Given this list of marker genes NAA15, RNF111, CDH22, CCNT2, NINL, PLAG1, LRRC4C, PPP2R5E, ZBTB4, TMEM161B, RNF141, KIN, SMARCA2, FAM222A, RBL2, NOVA1, TSPAN5 (tetraspanin 5), EDEM3, SIK2, ADAMTSL3, SRF, CDC42, SOBP (sine oculis binding protein homolog), USP11, RREB1, SLC4A4, SLC26A9, DNMT3A, FOS, PDS5B, CDK17, ACTG1, NACC1, ABCA1, MTOR (mechanistic target of rapamycin kinase), FXR1, GOLGA8B, ARHGAP24, RAB2B, ZFAND4, GOLGA6L9, C1orf21, EBF3, AEBP2, MAN2A1, WSB1, KCNMB2, ANK2, CBL, LUC7L3, KDM3A, CTDSPL2, HECTD2, NID2, PDIK1L, TAB2, FNBP1L, KDM6A, SNN, TOP1, ATP1B2, TACC2, MAP6, SPAST, NXPH1, AKIRIN1, GOLGA8A, MEIS2, STAT6, EML4, GFPT2, TNRC6B, RNF139, AFF4, HOXA9, GOLGA8EP, LRRC1, CSNK1G1, CPEB4, DLG3, ZEB1, MANEAL, MBD6, AFAP1, PTX3, NAT14, GLT8D2, PTPN5, DCBLD2, MET, EHD3, BZW1, TGIF2, ZNF638, ADGRG2, VEGFA, ARID4B, PROSER1, CAMTA1 (calmodulin binding transcription activator 1), FAM193A, FOXQ1, ATF3 (activating transcription factor 3), ARRDC3, NAA25, ITGB8, SCUBE3, CALCRL, PDGFRA, CCM2, PLOD2, YTHDC1, PHF6, RBM39, RUNX1, BAZ2B, SEMA6C, ASCL1, VLDLR, CITED2, ARHGAP20, BRSK2, SUB1, LIFR, C6orf62, DGKI, PPP1R12A, SUMO3, GOLGA4, ZHX1, QKI (QKI, KH domain containing RNA binding), SLCO5A1, FN1, PSD2, WAPL, CXXC5, NRP2, DPY30, GOLGA8G (NCBI Gene Id 653300), ZBTB18, KCNK1, MBNL1, PHF12, PHLPP2, TAF5, MEF2D, FGF12, SIPA1L3, ZNF654, LZTS3, GABRA4, RBM25, MAP2K1, ARHGAP21, DPP10, AKT3, SLC7A6, FOXP1, PI4K2B, ZNF706, CD24, VCAN, SECISBP2L, SORCS3, BTBD7, HYOU1, UXS1, GPM6A, CHD7, TANC1, PLEKHH1, BMP2, DPP4, GALNT18, AP1G1, ATP1B1, ETV1, TGIF1, APLP2, RLIM, GIGYF2, ACVR2A, NFE2L2, MAP3K4, here is a description of the gene set: studied in species Homo sapiens Human Gene Set: CTACTGT_MIR199A Genes having at least one occurence of the motif CTACTGT in their 3' untranslated region. The motif represents putative target (that is, seed match) of human mature miRNA hsa-miR-199a* (v7.1 miRBase).